The following is a description of a gene set: Any process that modulates the frequency, rate or extent of intrinsic apoptotic signaling pathway in response to DNA damage by p53 class mediator. Human Gene Set: GOBP_REGULATION_OF_INTRINSIC_APOPTOTIC_SIGNALING_PATHWAY_IN_RESPONSE_TO_DNA_DAMAGE_BY_P53_CLASS_MEDIATOR studied in species Homo sapiens, and this is the list of marker genes: ZNF385A, TAF9, CD44, ING2, MARCHF7, TRIAP1, BCL2, TP73, HNRNPK, MIF, MUC1, BCL2L12 (BCL2 like 12), RPL26, TAF9B, ELL3, CD74 (CD74 molecule), ATAD5, SIRT1, KDM1A